Given this list of marker genes PHIP, TMOD3, ACTG1, RHOBTB2, TRA2B, MSI2, HSP90AA1, MYO6, CCT6A, STK38, CDC37, CCT2, DDX39B, CUL3, HNRNPC, DBN1, RBMX, SRRM1, TXNL1, HSP90AB1, ACTN1, TWF1, CCT7, here is a description of the gene set: Human Gene Set: REACTOME_RHOBTB2_GTPASE_CYCLE RHOBTB2 GTPase cycle studied in species Homo sapiens